The following is a description of a gene set: studied in species Mus musculus Cytokines mediate cell-cell communication in the immune system and represent important therapeutic targets. A myriad of studies have highlighted their central role in immune function, yet we lack a global view of the cellular responses of each immune cell type to each cytokine. To address this gap, the authors created the Immune Dictionary, a compendium of single-cell transcriptomic profiles of more than 17 immune cell types in response to each of 86 cytokines (>1,400 cytokine-cell type combinations) in mouse lymph nodes in vivo. A cytokine-centric view of the dictionary revealed that most cytokines induce highly cell-type-specific responses. For example, the inflammatory cytokine interleukin-1β induces distinct gene programmes in almost every cell type. A cell-type-centric view of the dictionary identified more than 66 cytokine-driven cellular polarization states across immune cell types, including previously uncharacterized states such as an interleukin-18-induced polyfunctional natural killer cell state. Genes negatively differentially expressed in cell type: cDC1 (conventional dendritic cell type 1) upon treatment with cytokine: IL-3 in mouse lymph nodes in vivo. Mouse Gene Set: CUI_CDC1_IL3_RESPONSE_DN from publication Cui A, Huang T, Li S, Ma A, Pérez JL, Sander C, Keskin DB, Wu CJ, Fraenkel E, Hacohen N (PMID 38057668), and this is the list of marker genes: Zfp36l1, Klf6, Gdi2, Rnd3, Tbc1d9, Ifngr1, Atf3, Niban1, Cd47, Mef2c, Btg2, Ramp1, Fosb (FBJ osteosarcoma oncogene B), Ptpn18, Cox7a2l, Fnbp1, Clk1, Klf4, Ccr2, Sod1, Arhgap17, Foxp1, Treml4, Rab11fip1 (NCBI Gene Id 75767), Pak1, Uba52, Parp8, Rgs2, Rgs1, Rgs10, Eif3e (eukaryotic translation initiation factor 3, subunit E), Hspa1a, Rtl8a, Gpr65, Tsc22d3, Cytip, Zfp36l2, Arid4a, Lyz2, Clec12a, Mctp1, Txnip, Arsb, Itm2b, Ier5, Cd37, Klhl24 (NCBI Gene Id 98030), Alox5ap, Nsa2, Anp32a, Nr4a2, Pmaip1, Hepacam2, Kctd12, Ppp1r15a, Neat1, Klf2, Pld4, Rnase6, Fxyd5, Smpdl3a, Creg1, Cd180, Jun, St8sia4, Mpeg1, Ccnl1 (cyclin L1), Sult1a1, Mink1, Igbp1, Dusp1, Fgl2, Itgb7, Laptm5, Crebrf, Pold4, Arhgap15, Rhob, Cd81, H2-Q7, Ctsh, Samd9l, Fos, Pid1 (NCBI Gene Id 98496), Npc2, Trf